The following is a description of a gene set: studied in species Homo sapiens Human Gene Set: KEGG_MEDICUS_VARIANT_MUTATION_CAUSED_ABERRANT_ABETA_TO_MACHR_CA2_APOPTOTIC_PATHWAY Mutation-caused aberrant Abeta to mAchR-Ca2+ -apoptotic pathway. Pathway ID: N01001. Pathway type: Variant. Pathway class: nt06460 Alzheimer disease. Pathway Definition from KEGG: APP* -> Abeta -> mAChR -> GNAQ -> PLCB -> IP3 -> ITPR -> Ca2+ -- MCU -> Ca2+(mito) -- MPTP -> CYCS, and this is the list of marker genes: CHRM3, CHRM1, APP, PLCB3, SLC25A5 (solute carrier family 25 member 5), VDAC3, MCU, ITPR3, CHRM5, VDAC1, VDAC2, SLC25A4, SLC25A6 (NCBI Gene Id 8283), GNAQ, ITPR1, PLCB1 (NCBI Gene Id 23236), ITPR2, CYCS, PLCB2, PLCB4, SLC25A31